Given this list of marker genes CAP2, PFN2, PLS3, TLN2, DAAM1, PCLO, CLASP2, here is a description of the gene set: studied in species Homo sapiens Human Gene Set: GOBP_PRESYNAPTIC_CYTOSKELETON_ORGANIZATION A process that is carried out at the cellular level which results in the assembly, arrangement of constituent parts, or disassembly of cytoskeletal structures and their associated proteins in the presynaptic cytoskeleton.